The following is a description of a gene set: Genes having at least one occurence of the motif ACGCACA in their 3' untranslated region. The motif represents putative target (that is, seed match) of human mature miRNA hsa-miR-210 (v7.1 miRBase). studied in species Homo sapiens Human Gene Set: ACGCACA_MIR210, and this is the list of marker genes: DENND6A, EFNA3, ZNF827, SYNGAP1, ACVR1B, ELFN2, GPD1L, SCRT1